Given this list of marker genes E2F8, CENPM, MKI67, UBE2C, KIF24, RRAD, COX18 (NCBI Gene Id 285521), CDK1, PDZD9, RBM3, ESPL1, CDC25B, HASPIN, KDF1, TAMM41, PARP12 (poly(ADP-ribose) polymerase family member 12), GLIS2, BIRC5, NRM, CENPQ, UCHL3 (NCBI Gene Id 7347), SUGP2, KIF22, DDIAS, OR52N4, LBR, GPN1, SCN4B, DBNDD2, NCAPG2, PTPN13, PSMC3, MKX, CIT, KRTAP13-1, SPAG5, CENPV, GLE1, LGALS3BP, PRM2, CAPNS1, CYP20A1, STMN1, CRIP1, METRN, PLAU, VRK1 (NCBI Gene Id 7443), MIS18BP1, SELENOH, PSRC1, RNASEH2B, NUSAP1, BBOF1, L1CAM, HPX, IFT27, CNP, CDCA3, SLC10A2, BRCA1, ECI2, UBE2S, ADCY4, PIH1D1, LSM6, MAD2L1, SLC7A2, ASPM, DDB2, SNCG, E2F2, SRSF7, MRPS10, CCAR2, HAUS6, POC1A, RFC4, MCM7, MCM5, CASK, RTEL1, SFPQ, PTTG1, WDR62, CCDC12, BABAM1, SKA3, PKMYT1, CENPN, HHAT, PTPA, DCAF15 (NCBI Gene Id 90379), TOPBP1, PPIH (NCBI Gene Id 10465), RFC5, TUBA8, TSSK2, CORO1A, NDUFS8 (NADH:ubiquinone oxidoreductase core subunit S8), IMPDH2, DCXR, ST18, FKBP2, PRIM2, MRPS11, NTAN1, TAF1B, PDCL2, E2F1, CDCA8, NSMCE1, SUCLG2, CAPS2, KCNV2, ANAPC15, FXN, MFSD10, CEP89 (centrosomal protein 89), GRK6, POLE, NUBP1, SGO2 (NCBI Gene Id 151246), GAS2L3, GUCD1, PRPS1, NELFCD, POLA1, CKS1B, RACGAP1, NUP210, TEX9, CENPL, SKA1, CCNB2, HEATR1 (HEAT repeat containing 1), KIF4A, HJURP (Holliday junction recognition protein), CENPH, CHAF1B, PMF1, HAUS4, FBXO5, PCNT, SLC14A1, KRTAP3-3, KCNE3, POLE4, CENPF, FCGRT, ZBTB8B, TCIRG1, SMC4, HIRIP3, MAZ, ABCA7, RNF26, DBF4, TRAIP, DEK, FRMPD1, AMOTL1, KIF23, CKAP2L, CENPP, LPXN, FABP2, HOXD9, ZDHHC2, STIL, CEP128, IQGAP3, RBBP8, NEK2, CCSAP, SLBP, SUV39H1, SLC30A4 (NCBI Gene Id 7782), ARHGAP11A, HPF1, PACS2, HNRNPA2B1, VXN, SEMA3D, NRP1, CASKIN2, FOXM1, MASTL, HDAC6, CHTF18, CZIB, TLL2, PRR11, TC2N, MRPL47, PHF19, GINS2, NCAPD2, TACC3, ACKR3, YTHDF2, here is a description of the gene set: Induced Treg (iTreg) cells are essential for tolerance and can be used therapeutically, yet their stability in vivo and mechanisms of suppression are unresolved. Here, we used a treatment model of colitis to examine the role of autologous IL-10 in iTreg cell function. Mice treated with IL-10+/+ iTreg cells in combination with IL-10–/– natural Treg (nTreg) cells survived and gained weight, even though iTreg cells were numerically disadvantaged and comprised just ~20% of all Treg cells in treated mice. Notably, ~85% of the transferred iTreg cells lost Foxp3 expression (ex-iTreg) but retained a portion of the iTreg transcriptome which failed to limit their pathogenic potential. The TCR repertoires of iTreg and ex-iTreg cells exhibited almost no overlap, which indicates that the two populations are clonally unrelated and maintained by different selective pressures. These data demonstrate a potent and critical role for iTreg cell produced IL-10 that can supplant the IL-10 produced by nTreg cells and compensate for the inherent instability of the iTreg population. Genes up-regulated in comparison between in vitro derived induced T reg (iTreg) and converted ex iTreg. from publication Schmitt EG, Haribhai D, Williams JB, Aggarwal P, Jia S, Charbonnier LM, Yan K, Lorier R, Turner A, Ziegelbauer J, Georgiev P, Simpson P, Salzman NH, Hessner MJ, Broeckel U, Chatila TA, Williams CB (PMID 23125413) species: Homo sapiens Human Gene Set: GSE35543_IN_VITRO_ITREG_VS_CONVERTED_EX_ITREG_UP